The following is a description of a gene set: Human Gene Set: GOBP_MESENCHYMAL_STEM_CELL_MAINTENANCE_INVOLVED_IN_NEPHRON_MORPHOGENESIS The process in which an organism retains a population of mesenchymal stem cells that contributes to the shaping of a nephron. A mesenchymal stem cell is a cell that retains the ability to divide and proliferate throughout life to provide progenitor cells that can differentiate into specialized mesenchymal cells. studied in species Homo sapiens, and this is the list of marker genes: PAX8, WNT9B, PAX2, HNF1B, BMP7 (NCBI Gene Id 655, bone morphogenetic protein 7), SIX2